The following is a description of a gene set: Phosphatidylserine (PS) is synthesized by facilitating the exchange of L-Serine (L-Ser) with the choline (Cho) head group in phosphatidylcholine (PC) and with the ethanolamine (ETA) head group in phosphatidylethanolamine (PE). studied in species Homo sapiens part of: Glycerophospholipid biosynthesis Reactome Pathway: Synthesis of PS, and this is the list of marker genes: PTDSS1, PTDSS2